The following is a description of a gene set: Genes down-regulated in comparison of macrophages versus effector memory CD4 T cells. species: Homo sapiens Human Gene Set: GSE3982_MAC_VS_EFF_MEMORY_CD4_TCELL_DN In the present study we used Affymetrix oligonucleotide microarrays to produce gene transcription profiles for the major leukocyte types in humans. This comprehensive dataset enabled us to not only establish which genes were expressed in each leukocyte type, but also which genes were expressed in each subset after activation. The used of a comprehensive dataset of gene profiles from all the major human leukocyte subsets enabled a novel and powerful means for identification of genes associated with single leukocyte subsets, or different immune paradigms. from publication Jeffrey KL, Brummer T, Rolph MS, Liu SM, Callejas NA, Grumont RJ, Gillieron C, Mackay F, Grey S, Camps M, Rommel C, Gerondakis SD, Mackay CR (PMID 16474395), and this is the list of marker genes: DUS4L, AKAP9, BGN, HTR1A, PPP1R12B, E4F1, MTNR1B, TNK1, ACSM3, ZNF574, FXR1, CISH, KCNN3, NKX3-2 (NCBI Gene Id 579), CEP68, IL18RAP, CTAGE9, KIR2DS3, LRRC3, CYP11B1, HSPA1L, DCAF8, SEC24C, PRPH2, NR2F2, RPL4, ELAVL3, MVB12B, SLC10A3, DHX9, CABP5 (NCBI Gene Id 56344), IL26, CROCCP2, SYNE1, FLT3LG, ZNF665, CYP17A1, KRT83, ZC3H7B, KIFAP3, SULF1, SERPINB10, TRIM13, CDH10, TUG1, FNBP4, OR1D2, TCF20, FAM30A, PRMT2, DEF6, BRD8, PMS2P3, DDX50, ANKH, TNK2, BCOR, TREH, ABHD17A, CATSPERZ, CD38, CSRP3, RPL35A, RNF125, CHRM2, GLG1, CXCL11, EZR, EPHA2, PEX1, GZMM (NCBI Gene Id 3004), TMEM80, DAP3, TRPC4AP, OR2H1, PRKACA, STXBP6, TLL2, PTBP2, SLC6A2, SLC41A3, MTERF1, KCNK1, MYH15, ESR2, NOTCH4, RANGRF, AMACR, HSF2, FN3KRP, GRPR, QSER1, HYOU1, SHBG, PASK, PMF1, MYO9A, HOXB9, SNTG1, POFUT2, ARPC5L, CEP250, EFEMP2, RPS6, RIBC2, KHDC1L, SP140, PIAS3, NYNRIN, MCC (MCC regulator of WNT signaling pathway), SRSF4 (NCBI Gene Id 95902), SMPDL3B, NR3C1 (NCBI Gene Id 389335), ENO3, DDHD2, EIF3I, KIF21B, PAX1 (NCBI Gene Id 5075), PBX2, CYP24A1, TPH1, IFNG, CXCR6, LIM2, ATM, CREB1, MAPK8IP3, MEF2D (NCBI Gene Id 4209), R3HCC1, COQ8A, RXYLT1, PARP8, LAS1L, CA6, MPPED1, ZNF365, TGFBR3, PKD1P1, LTK, HOPX, INPP4A, RPL32, FYN, FBXO21, CCNP, DDX23, PRKD2 (NCBI Gene Id 51519), GDF3, IFI16, MUC2, PDE10A, SPAM1, TMEM212, LHB, ZNF14, STOML1, PTPRN, ANKRD7, DBT, NDST3, IRF4, TMSB15B, LSAMP, RASSF1, MCL1, EPPIN, OSBPL3, PLEKHG3, PLEKHF1, CALML5, NUFIP1, ALDH8A1, PBXIP1, ZNF184, NDRG1, HMGN1, XKR8, ZBTB14, PDE4B, MAN2A2, YY1AP1, SH2B1, FBXO41, GAR1 (NCBI Gene Id 54433), GGA2, YAF2, BTN2A1, SRPX, ALDOAP2 (ALDOA pseudogene 2), PDGFD, RPL10L, CTLA4, SRCAP, LONP2, CD40LG, RBCK1